Given this list of marker genes Hmox1, Mmrn2, Map3k3, Micall1, Fgfbp1, Fbxw7, Mia3, Abl1, Itgb1, Mmrn1, Adtrp (NCBI Gene Id 77346), Clec14a, Nrp1, Spred1, Slit2, Nr4a1, Jcad, Pdcd10, Klf4, Itgb1bp1, Thbs1, Card10 (caspase recruitment domain family, member 10), Foxc2, Ctnnd1, Pacsin2, Ephb4, Fgf2, Meox2, Notch1, Ehd4, Akt3, Rhoa, Pik3r2, Rhoj, Vegfa, Robo1, Hdac9, Pik3c2a, Map2k5, Efnb2, Dll4, Pik3r3, Srpx2, Gpld1, Tgfbr3, Stard13, Anxa1, Nr2e1, Ptgs2, Akt1, Grem1, Cdh5, Kdr, Plk2, Egr3, Gata2, Srf, Cib1, Tbxa2r, Hdac7, Hdac5, here is a description of the gene set: Mouse Gene Set: GOBP_CELL_MIGRATION_INVOLVED_IN_SPROUTING_ANGIOGENESIS species: Mus musculus The orderly movement of endothelial cells into the extracellular matrix in order to form new blood vessels involved in sprouting angiogenesis.